The following is a description of a gene set: Human Gene Set: HP_ABNORMALITY_OF_SKULL_OSSIFICATION Abnormality of skull ossification species: Homo sapiens An abnormality of the process of ossification of the skull., and this is the list of marker genes: RBL2, LAMA5, FAM111A, FIG4, ALG9, THPO, ZMPSTE24, BMPER, ALX4, MPL, TRIP11, NAGLU, EXT2, P3H1, TBCE, TAPT1, SEC23A, COL1A2, PHF21A, IFT43, COL2A1, VAC14 (VAC14 component of PIKFYVE complex), HDAC6, PPIB, HHAT, WNT7A, ANTXR1, ALPL, CREB3L1 (cAMP responsive element binding protein 3 like 1), SERPINH1, SGSH, TXNDC15, NOTCH2, CRTAP, VCP, INTU, LMNA, SLC25A19, RUNX2, PPP3CA, LBR, OSTM1, SLC25A24, FGFR2 (fibroblast growth factor receptor 2), HGSNAT, CSF1R, COL1A1